Given this list of marker genes Stk4, Faf1, Mal (myelin and lymphocyte protein, T cell differentiation protein, NCBI Gene Id 17153), Thbs1 (thrombospondin 1), Atf3, Stk3, Zswim2, Bmpr1b, Skil, Pmaip1, Sfrp1, Psen2, Trps1, Pea15a, here is a description of the gene set: Mouse Gene Set: GOBP_POSITIVE_REGULATION_OF_EXTRINSIC_APOPTOTIC_SIGNALING_PATHWAY_VIA_DEATH_DOMAIN_RECEPTORS studied in species Mus musculus Any process that activates or increases the frequency, rate or extent of extrinsic apoptotic signaling pathway via death domain receptors.